Given this list of marker genes KIF15, ROR2, GDF5, NOG, BHLHA9, here is a description of the gene set: Human Gene Set: HP_ABNORMALITY_OF_THE_PROXIMAL_PHALANX_OF_THE_5TH_FINGER species: Homo sapiens Abnormality of the proximal phalanx of the little (5th) finger. Abnormality of the proximal phalanx of the 5th finger